The following is a description of a gene set: The process of shaping a trabecula in bone. A trabecula is a tissue element in the form of a small beam, strut or rod. species: Homo sapiens Human Gene Set: GOBP_BONE_TRABECULA_MORPHOGENESIS, and this is the list of marker genes: RHOA, COL1A1, GREM1 (NCBI Gene Id 7947), MSX2, FBN2, THBS3, CHAD (chondroadherin), MMP2, VEGFA, SFRP1, WNT10B, SEMA4D, SBNO2